The following is a description of a gene set: Binding to a Wnt-protein, a secreted growth factor involved in signaling. Mouse Gene Set: GOMF_WNT_PROTEIN_BINDING studied in species Mus musculus, and this is the list of marker genes: Apcdd1, Sfrp2, Sfrp5 (NCBI Gene Id 54612), Fzd2, Reck, Ror1, Fzd1, Musk, Ryk, Cthrc1, Wif1, Fzd6, Lrp6, Ptpro, Frzb, Wls, Sfrp4, Porcn, Cripto, Sfrp1 (NCBI Gene Id 72362), Ror2, Fzd10, Fzd7, Fzd9, Fzd4, Fzd5, Lrp5, Fzd8, Fzd3, Trabd2b